Given this list of marker genes PHOX2B, SFRP1, CTNNB1, FERD3L, WNT3, VEGFA, GSK3B, LMX1A, CDNF, LMX1B, RYK, TIAM1, WNT3A, VEGFD, WNT5A, HPRT1, OTX2, FGF8, PITX3, WNT2, ID2, MANF, OTP, HIF1A (hypoxia inducible factor 1 subunit alpha), SMO, NR4A2, EN1, SFRP2, FOXA2, SHH, DKK1, EN2, PHOX2A, FOXA1, FMC1, DMRTA2, WNT9B, RSPO2, WNT1, FGF20, FZD1, RAC1, LRP6, CSNK1D, here is a description of the gene set: Human Gene Set: GOBP_DOPAMINERGIC_NEURON_DIFFERENTIATION studied in species Homo sapiens The process in which a neuroblast acquires the specialized structural and functional features of a dopaminergic neuron, a neuron that secretes dopamine.